Given this list of marker genes Nr1h4, Pik3ap1, Tlr9, Unc93b1 (NCBI Gene Id 54445), Rsad2, Tnip2, Zdhhc3, Rab7b, Slc15a4, Treml4, Epg5, Ptprs, Ptpn22, Cd300ld3, Havcr2, Rtn4, Gramd4, Hmgb1, Ppt1, here is a description of the gene set: The series of molecular signals initiated by a ligand binding to the endolysosomal toll-like receptor 9. Mouse Gene Set: GOBP_TOLL_LIKE_RECEPTOR_9_SIGNALING_PATHWAY studied in species Mus musculus